The following is a description of a gene set: species: Homo sapiens Human Gene Set: HP_FALCIFORM_RETINAL_FOLD Falciform retinal fold An area of the retina that is buckled so that a sector-shaped sheet of retina lies in front of the normal retina. This feature is of congenital onset., and this is the list of marker genes: CTNNB1, ZNF408, NDP, LRP5, FZD4, TSPAN12